The following is a description of a gene set: Mouse Gene Set: GOMF_PHOSPHATIDYLSERINE_BINDING Binding to phosphatidylserine, a class of glycophospholipids in which a phosphatidyl group is esterified to the hydroxyl group of L-serine. studied in species Mus musculus, and this is the list of marker genes: Syt1, Syt3, Timd2, Syt5, Anxa7, Anxa1, Anxa9, Mme, Gramd1b, Gsdma, Syt6, Appl1, Osbpl5, Cpne6, Anxa8, Syt7, Appl2, Timd4, Anxa6, Osbpl10, Dppa1, Adgrb1, Hspa8, Scarb2, Gsdma3, Gap43, Cd300lf, Sytl2, Rpe65, Mark1, Hmgb1, Rs1, Mfge8, Timd5, Marcks, Fcho2, Anxa11, Smpd3, Scarb1, Asap1, Gas6, Axl, Anxa3, Jph2, Gsdmd, Havcr1, Anxa10, Cavin2, Gsdma2, Gsdmc2, Gsdmc, Trem2, Syt4, Plekhn1, Cidec, Cd300a, Timd6, Osbpl8, Anxa5, Syt2, Thbs1, Gsdmc4, Anxa2, Tln1, Cpne1, Anxa4, Syt9, Syt10, Gsdmc3, Anxa13, Trim72